The following is a description of a gene set: Any process that modulates the frequency, rate or extent of the regulated release of a neurotransmitter from a cell. Mouse Gene Set: GOBP_REGULATION_OF_NEUROTRANSMITTER_SECRETION studied in species Mus musculus, and this is the list of marker genes: Ppfia2, Sncg (synuclein, gamma), Fbxl20, Slc4a8, Bcl2l1, Snapin, Cask, Syt4, Mef2c, Drd4, Sncaip, Kcnc4, Cplx3, Atp2a2, Rims4, Vps18, Syt8, Mctp1, Stxbp1, Rap1b, Cacna1d, Stxbp5l, Rab3gap1, Git1, Syt1, Rab5a (NCBI Gene Id 66987), Pfn2, Cacna1b, Hcrt, Unc13b, Snap29, Prepl, P2ry2 (purinergic receptor P2Y, G-protein coupled 2), Adora2a, Asic1, Stx1b, Micu3, Bglap, Syn1 (NCBI Gene Id 20964), Tspoap1, Ncs1, Mctp2, Cacna1a, Rhot1, Syt13, Bglap2, Npy, Cacna1e, Fbxo45, Ggcx, Kmo, Ptger4, Ica1, P2ry1, Lrrk2, Npy1r, Kcnh1, Ngf, Snca, Syt5, Kcnc3, Grm8, Rims2, Rap1a, Htr2c, Fmr1, Cplx4, Ntrk2, Gpr158, Htr1d, P2ry4, Stx1a, Slc18a3, Gper1, Rab3a, Ppp1r9a, Gpr151, Dtnbp1, Tprg1l, Chrna3, Wnt7a, Dvl1, Rims1, P2rx1, Sphk1, P2rx7, Edn3, Cacnb4, Unc13a, Stxbp5, Prkcb, Slc30a1, Htr6, Prkn, Htr1b, Prkca, Syt2, Baiap3, Prkcg, Slc38a2, Braf, Rims3, Sv2c, Pnkd, P2rx2, Cspg5, Dnm1l, Git2, Sv2b, Tacr2, Nf1, Nlgn1, Camk2a